The following is a description of a gene set: Human Gene Set: GSE2405_0H_VS_12H_A_PHAGOCYTOPHILUM_STIM_NEUTROPHIL_UP Polymorphonuclear leukocytes (PMNs) were obtained from healthy individuals in accordance with protocols approved by the Institutional Review Board for Human Subjects at the University of Minnesota and the National Institute of Allergy and Infectious Diseases. PMNs (107) were combined on ice with live S. aureus (108) or with live or heat-killed A. phagocytophilum (bacteria isolated from 5x106 infected HL60 cells for a ratio of 1 infected HL60 cell: 2 PMNs, ~ 5-20 A. phagocytophilum: PMN) in wells of a 12-well tissue culture plate (pre-coated with 20% autologous normal human serum). Unstimulated control assays received either buffer (for S. aureus comparisons) or clarified HL60 lysate (for A. phagocytophilum comparisons). Plates were centrifuged at 350 x g for 8 min at 4oC to synchronize phagocytosis and incubated at 37 deg. C in a CO2 incubator for the indicated times. At the indicated times, tissue culture medium was aspirated from the plate and PMNs were lysed directly with RLT buffer (Qiagen, Valencia, CA). Purification of PMN RNA and subsequent preparation of labeled cRNA target was performed as described in Methods. Labeling of samples, hybridization of cRNA with HU133A oligonucleotide arrays (Affymetrix, Santa Clara, CA), and scanning were performed according to standard Affymetrix protocols ( http://www.affymetrix.com/pdf/expression_manual.pdf ). Experiments were performed in triplicate, using PMNs from three healthy individuals for each treatment. species: Homo sapiens Genes up-regulated in polymorphonuclear leukocytes (12h): control versus infection by A. phagocytophilum. from publication Borjesson DL, Kobayashi SD, Whitney AR, Voyich JM, Argue CM, Deleo FR (PMID 15879137), and this is the list of marker genes: EPHX1, MAP3K3, BIN1, MYO6, PXYLP1, TGFBR2, COL23A1, CCND2, DDC, HVCN1, DDX60, NR4A1, IER5, INPP5B, ENC1, ARHGAP1, DENND2D, PACS2, OASL, B4GALNT1, IRF4, SPN, IL2RB, CYTH4, TNFRSF1B, ECM1, ITGB3, RGS19, TRIB2, EEIG1, FLT3LG, CARD11, STING1, TRIO, C3orf80, RFTN1, GLIPR2, CD7, RFLNB, UTP14A, ST3GAL2, ARRB2 (arrestin beta 2), TNFSF11, CTSW, IGF2R, DNAAF4, EGR2, DAPL1, C8orf76, HS3ST3B1, RAP1B, TLR1, FMNL3, PRF1, TRIM26, GPR146, ZCCHC12, KLF2, MYD88, HLA-B, TRAPPC14, SEMA4F, GIMAP7, CD48, CD200R1, NOD1, GNG2, GALNT6, GPR18, IRF7 (NCBI Gene Id 3665), IFI35, ID2, PRDX6, RSAD2, ZNF467, RELB, XCL1, CHCHD10, CAPG, LACTB, IZUMO1R, BCL2, IFIT3, ACTN2, XAF1, NFATC2, PARP3, ADCK5, GPRIN3, JAK3, PML, GADD45G, CMTR1, PSEN2, ARPC5L, COTL1, PCBP4, SELL, RASA3, ASAP1, IGFLR1, TAP1, GM2A, FOXO1, FAM118A, PTGER2, CRYBG1, PPP1R13B, LY9, FAAH (NCBI Gene Id 2166), TREML2, CAST, PACSIN1, CD82, SGMS1 (NCBI Gene Id 93538), S1PR1, SMAD7, STK24, ITGB2, RASAL3, CMPK2, RCAN3, TESC, N4BP2L1, SEMA4A, FAM3C, SLC39A14, TMEM63A, PARP14, AP1G2, ARMC7, PIGS, ATAD3A (ATPase family AAA domain containing 3A), CARD6, RIGI, CNN2, SCAMP3, TRIM14, IRF9, POLR1B, IL21, TSPAN9, ST6GAL1, PGLYRP2, TOX2, CCR7, CHD7, IL6R (NCBI Gene Id 3570), TRPM1, RGS1, TNFRSF4, GALNT10, NXPE3, S1PR4, IKZF4, TAPBP, KLHL25, PTGIR, ANXA6, GDPGP1, INPP1, SLFN5, VSIR, RETREG1, RUNX3, ARHGEF18, ARL6IP5, STAT1, CST7, ARHGAP20, IPO4, PRKCH, CCR8, GRK6, NKG7, ITGAE, TSPAN31, NAB2, FRMD8, NFKB1, CRTAM, TMEM64, ENTREP3, PPP1R18, CD200, PSME2, B3GALT4, CCDC88C, ATP1B3, MLLT6, EHD3, PYROXD2, RIN3, CRLF2, GPR65, DAP, QSOX1, PTGFRN, FOXP3